Given this list of marker genes KRT14, CASP10 (NCBI Gene Id 843), DAPK1, SEPTIN7, PTPRF, DSG1, RPSA (NCBI Gene Id 3921), MMP17, KRT1, MAP3K14, CD9, NME2, KRT13, NME1, KRT10, here is a description of the gene set: species: Homo sapiens Genes up-regulated in primary keratinocytes at 1 h after UVB irradiation. from publication Murakami T, Fujimoto M, Ohtsuki M, Nakagawa H (PMID 11532376) Human Gene Set: MURAKAMI_UV_RESPONSE_1HR_UP Ultraviolet B irradiation initiates and promotes skin cancers, photo-aging, and immune suppression. In order to elucidate the effect of these processes at the level of gene expression, we used cDNA microarray technology to examine the effect of ultraviolet B irradiation on 588 cancer-related genes in human keratinocytes at 1, 6, and 24 h post-irradiation with a mildly cytotoxic dose of ultraviolet B (170 mJ/cm(2)). The viability of the irradiated keratinocytes was 75% at 24 h post-irradiation. Various cytokeratins and transcription factors were up-regulated within 1 h post-irradiation. After 6 h, expression of a variety of genes related to growth regulation (e.g. p21(WAF1), notch 4, and smoothened), apoptosis (e.g. caspase 10, hTRIP, and CRAF1), DNA repair (ERCC1, XRCC1), cytokines (e.g. IL-6, IL-13, TGF-beta, and endothelin 2), and cell adhesion (e.g. RhoE, and RhoGDI) were altered in human keratinocytes. These data suggest the changes in a cascade of gene expression in human keratinocytes occurring within 24 h after UVB exposure. Although the roles of these cellular genes after UVB-irradiation remain to be elucidated, microarray analysis may provide a new view of gene expression in epidermal keratinocytes following UVB exposure.